Given this list of marker genes Zfp36, Dcp2, Dcp1a, here is a description of the gene set: electronically inferred by orthology from the curated human pathway species: Mus musculus This event has been computationally inferred from an event that has been demonstrated in another species.<p>The inference is based on the homology mapping from PANTHER. Briefly, reactions for which all involved PhysicalEntities (in input, output and catalyst) have a mapped orthologue/paralogue (for complexes at least 75% of components must have a mapping) are inferred to the other species. Reactome Pathway: Tristetraprolin (TTP, ZFP36) binds and destabilizes mRNA part of: Regulation of mRNA stability by proteins that bind AU-rich elements